Given this list of marker genes Cdkn1b, Rere, Ints9, Trib3, Acvr1, Nupr1, Ube2h, Dbp, Sgf29, Rarg, Ralgds, Herpud1, Cdk1, Mpdz, Pdk4, Sesn1, Gadd45a, Mmp11, here is a description of the gene set: Mouse Gene Set: SARTIPY_BLUNTED_BY_INSULIN_RESISTANCE_DN from publication Sartipy P, Loskutoff DJ (PMID 14530283) We have employed microarray technology using RNA from normal 3T3-L1 adipocytes and from 3T3-L1 adipocytes made insulin-resistant by treatment with tumor necrosis factor-alpha to identify a new class of insulin-responsive genes. These genes continued to respond normally to insulin even though the adipocytes themselves were metabolically insulin-resistant, i.e. they displayed a significantly decreased rate of insulin-stimulated glucose uptake. Approximately genes/expressed sequence tags (ESTs) were screened. Of these, genes/ESTs were identified that became insulin-resistant as expected (e.g. Socs-3, junB, and matrix metalloproteinase-11). However, genes/ESTs continued to respond normally to insulin. Although some of these genes were previously shown to be regulated by insulin (e.g. Glut-1 and beta3-adrenergic receptor), other novel insulin-sensitive genes were also identified (e.g. Egr-1, epiregulin, Fra-1, and ABCA1). Real-time reverse transcription-PCR analysis confirmed the expression patterns of several of the differentially expressed genes. One gene that remained insulin-sensitive in the insulin-resistant adipocytes is the transcription factor Egr-1. Using an antisense strategy, we show that tissue factor and macrophage colony-stimulating factor, two cardiovascular risk factors, are downstream EGR-1 target genes in the adipocyte. Taken together, these data support the hypothesis that some signaling pathways remain insulin-sensitive in metabolically insulin-resistant adipocytes. These pathways may promote abnormal gene expression in hyperinsulinemic states like obesity and type II diabetes and thus may contribute to pathologies associated with these conditions. studied in species Mus musculus Genes down-regulated in 3T3-L1 cells (adipocyte) by insulin but displayed blunted response to insulin the insulin resistant cells.